The following is a description of a gene set: species: Homo sapiens The controlled release of glutamate by a cell, in which the glutamate acts as a neurotransmitter. Human Gene Set: GOBP_GLUTAMATE_SECRETION_NEUROTRANSMISSION, and this is the list of marker genes: DTNBP1 (NCBI Gene Id 84062), ABCC8, KCNJ8, RAB3GAP1, STXBP1, NF1, SLC38A2, KMO